The following is a description of a gene set: Mouse Gene Set: GOBP_ENSHEATHMENT_OF_NEURONS The process in which glial cells envelop neuronal cell bodies and/or axons to form an insulating layer. This can take the form of myelinating or non-myelinating ensheathment. species: Mus musculus, and this is the list of marker genes: Kel, Erbb2, Hexa, Ntf3, Fgfr3, Mbp, Adam22, Myrf, S100b, Cst7, Cntn1, B4galt5, Tymp, Ilk, Rara (retinoic acid receptor, alpha), Mir138-1, Eif2b4, Ppard, Zfp24, Degs1l, Ifng, Mir24-1, Ncstn (nicastrin), Cntn2, Ormdl1, Pou3f2, Nrg1, Mir24-2, Ntrk3, Tsc1 (TSC complex subunit 1), Mios, Trf, Xk, Abcd2, Mir219a-1, Fa2h, Hnrnpk, Sirt2, Slc25a12, Tmem98, Afg3l2, Hgf, Cd9, Mir27b, Rnf10, Pomgnt1, Slc25a46, Tlr2, Amigo1, Tnfrsf1b, Cdk18, Aspa, Mir34a, Akt2, Pten, Cldn5, Mir338, Mir138-2, Rarg, Ctnnb1, Sh3tc2, Dlg1, Ngfr, Lpin1, Gpm6b, Itgb4, Nfasc, Mir23a, Tg, Ptprz1, Ppp3r1, Ulk4, Ercc2, Tspan2, Bcas1, Atrn, Acer3, Dag1, Tnf, Mobp, Cxcr4, Eif2ak3, Pllp, Sod1, Mtor, Mapk3 (NCBI Gene Id 26417), Rxra, Cntnap1, Olig2, Pou3f1, Omg, Iqschfp, Id4, Map2k2, Egr2, Tnfrsf21 (NCBI Gene Id 98092), Cdh2, Reg2, Raf1, Sos1, Psap, Ckap5, Sgms1os1, Adgrg6, Hycc1, Col6a1, Ski, Mtmr2, Mir100, Epb41l3, Tcf7l2, Large1, B4galt6, Erbb3, Prx, Srebf2, Mal2, Mag, Mapk1, Zfp488, Rxrb (NCBI Gene Id 20182), Pi4ka, Akt1, Mpdz, Nsun5, Mir23b, Tmem163, Dhh, Mpz, Hes5, Selenoi, Mir195a, Ccdc39, Itgax, Cntnap2, Jam3, Gnpat, 9630013A20Rik, Cmtm8 (CKLF-like MARVEL transmembrane domain containing 8), Rarb, Galc, Ndrg1, Wasf3, Mir219a-2, Ugt8a, Sox10, Lpar1, Mir146b, Cldn11, Mall, Zpr1, Mir140, Nab2, Nrdc, Jam2, Dicer1, Mir204, Kcnj10, Fig4, Eif2b5, Qki, Tgfb1, Gjc3, Plp1, Fyn, Ormdl3, Igf1, Plec, Abcd1, Ctsc, Rxrg, Ncmap, Arhgef10, Slc8a3, Ntrk2, Nf1, Eif2b2, Degs1, Pikfyve, Ptn, Pmp22, Serinc5, Map2k1, Myoc, Abca2, Pals1, Kif14, Mal, Tppp, Cyfip1, Gal3st1, Hexb, Mir30a, Nkx6-2, Tenm4 (teneurin transmembrane protein 4), Pard3, Lgi4, Marveld1, Grb2, Nab1, Myo5a, Clu, Gpc1, Hras, Enpp1